Given this list of marker genes Tnrc6a, Eif5, Slitrk1, Chd7, Trmt10a, Dmd, Tdrd5, Xpo1, Gpr155, Dynlt1a, Cebpa, Tbc1d15, Mrs2, Dpep1, Otud4, Folh1, Eda2r, Hoxb9, Alkbh8, Sec14l1, Kcnq5, Zfp112, Nlgn1, Mtm1, Zfp292 (zinc finger protein 292), Gabpb2 (NCBI Gene Id 99849), Setbp1, Tnrc6b, Pigw, Apcs, Kcnb1, Lmcd1, Nrxn1, D630045J12Rik, Tbc1d14, Celf4, Phlpp1, Dyrk3, Serpinb9e, Fgf14, Kcnmb1 (NCBI Gene Id 16533), Neurod1, Epc2, Numb, Trim36, Kdm1b, Slc20a2, Zbtb41, Dag1, Dennd5b, Rock1, Smpdl3b, P2ry1, Arpc5, Mb21d2, Dop1b, Pax6 (paired box 6), Adgrb3, Cdin1, Synj1, Tank (NCBI Gene Id 97021), Tcf4, Atf2, Ythdf3, Zfp322a, Serpinb9f, Samd4, Trps1, Wsb1, Trnt1, Setdb2, B3galnt2, Heca, Prdm16, Elavl4, Slc17a6, Rbak (NCBI Gene Id 57782), Mr1, Plaa, Gphn, Wdr44, Trp53inp1, Tor1aip1, Elovl5, Cacna1g, Myo5a, Cdkn1b, here is a description of the gene set: from publication Chen Y, Wang X (PMID 31504780) species: Mus musculus Genes predicted to be targets of miRBase v22 microRNA mmu_miR_190b_5p in miRDB v6.0 with MirTarget v4 prediction scores > 80 (high confidence targets). Mouse Gene Set: MIR_190B_5P